The following is a description of a gene set: Human Gene Set: RIZ_ERYTHROID_DIFFERENTIATION_HEMGN from publication Riz I, Akimov SS, Eaker SS, Baxter KK, Lee HJ, Mariño-Ramírez L, Landsman D, Hawley TS, Hawley RG (PMID 17213805) Selected gradually up-regulated genes whose expression profile follows that of HEMGN in the TLX1 Tet On iEBHX15-4 cells (pro-erythroblasts). studied in species Mus musculus Aberrant expression of the human homeobox-containing proto-oncogene TLX1/HOX11 inhibits hematopoietic differentiation programs in a number of murine model systems. Here, we report the establishment of a murine erythroid progenitor cell line, iEBHX1S-4, developmentally arrested by regulatable TLX1 expression. Extinction of TLX1 expression released the iEBHX1S-4 differentiation block, allowing erythropoietin-dependent acquisition of erythroid markers and hemoglobin synthesis. Coordinated activation of erythroid transcriptional networks integrated by the acetyltransferase co-activator CREB-binding protein (CBP) was suggested by bioinformatic analysis of the upstream regulatory regions of several conditionally induced iEBHX1S-4 gene sets. In accord with this notion, CBP-associated acetylation of GATA-1, an essential regulator of erythroid differentiation, increased concomitantly with TLX1 downregulation. Coimmunoprecipitation experiments and glutathione-S-transferase pull-down assays revealed that TLX1 directly binds to CBP, and confocal laser microscopy demonstrated that the two proteins partially colocalize at intranuclear sites in iEBHX1S-4 cells. Notably, the distribution of CBP in conditionally blocked iEBHX1S-4 cells partially overlapped with chromatin marked by a repressive histone methylation pattern, and downregulation of TLX1 coincided with exit of CBP from these heterochromatic regions. Thus, we propose that TLX1-mediated differentiation arrest may be achieved in part through a mechanism that involves redirection of CBP and/or its sequestration in repressive chromatin domains., and this is the list of marker genes: SOX1, CUX1, SOX18, POU2F3, MPL, NCOA1, E2F8, NFE2L3, NR0B2, POU3F3, EYA2, KLF5, ZNF436, HOXA2, TAL2, ELL2, FOXA1, NKX2-5, NR2F1, TMPO, SOX4, NR4A2, RUNX1T1, FOSB, TBX2, PBX3